Given this list of marker genes PRADC1, BICC1, HYPK, PPCS, ALG5, ZMPSTE24, TFB1M, TSEN2, VAPB, RPAP2, RAB14, PLPP5, CMPK1, SLC25A17, CACNA1F, FOXK2, SKIC8, XRCC6, NIP7, C11orf24 (NCBI Gene Id 53838, chromosome 11 open reading frame 24), FERRY3, MEMO1, RCC1, SGK2, CHST11, RRN3, RAPGEF5, NDUFB10, TCOF1 (treacle ribosome biogenesis factor 1), USP36, JAGN1, FBXL6, MRPL15, CLNS1A (NCBI Gene Id 1207), CEP55 (centrosomal protein 55), GARS1, DPY30, NHP2, C1D, SLC39A14, COQ9, GAS8, RGMA, GCAT, KIF20B, SOCS6, CNGB3, SH3PXD2B, PPIA, MRPS31, SLC36A4, BCAP29 (B cell receptor associated protein 29), DEPTOR, PRKCI, SLC36A1, UBFD1, RCC2, H2AZ1, FYTTD1, OPN1SW, PUM3, KDM4D, INPP5D, MPHOSPH10, TOP1MT, ATF5, DCTPP1, RAD17, DDX19B, EXOC2, EIF2B5, FADS6, IRF4, RAD51AP1, WDR12, CD5, PSMD1, PHF10, RNPS1, DAGLB, LIPT1, MYO7A, NDUFAF2, SEPTIN7, MYLK4, NDUFA13, SLC35A4, POP5, HACD1, MANF, EPPK1, PKM, PRIM2, TM6SF1, MTX2, MXD4, C2orf76, TDP1 (tyrosyl-DNA phosphodiesterase 1), CLPTM1L, NDUFS6, LRRC59, ATP5F1A, RPL10, C5orf24, GPR89B, BUB3, WASHC2A, CORO1C, WDR76, DDX20, PHTF2 (putative homeodomain transcription factor 2), HEATR1, GNAI3, PSMA1, RBM34, NUP85, TARS1, TSPY1, CIAO3 (cytosolic iron-sulfur assembly component 3), COPS7A, PYCR2, TYSND1, KDM2B, RIF1, GCSH, SDR39U1, BUD23 (NCBI Gene Id 84118), EXOSC1, KIF13A, CEP170B, E2F7, HCCS, NAA38, LALBA, NUP133, GNPAT (NCBI Gene Id 8443), RAP1GDS1, MPP3, SIRPA, PDE4DIP, UCHL5, TIMM10, PTGER2, KCNK7, ZWILCH, LBR, LPL, KNTC1, CELF5, CEBPZ, RBM28, SPRY3, DDX18, SET, GOLGA7, IL1RL2, NOP10, STRBP, NPM3, TARS2, MOB3B, STRAP, GLE1, GFM1, DLEU7, TFB2M, UBE2T, PIGY, KNL1, EMG1, LTV1, MANBA, CCDC47, MRPS9, TPM2, EIF3I, LCLAT1, IPMK, RPS6KA3, PPM1G, CCNA2, ZCCHC10, TATDN2, POPDC3, SLC4A7, NFU1, ATXN3, DHX29, SBK1, ATRN, ZSWIM7, RP9, MYADM, ALDH3A1, PRIM1, UTP4, EIF2B1, IMMT, P4HB, here is a description of the gene set: from publication Felker P, Seré K, Lin Q, Becker C, Hristov M, Hieronymus T, Zenke M (PMID 20881193) Dendritic cells (DCs) in lymphoid tissue comprise conventional DCs (cDCs) and plasmacytoid DCs (pDCs) that develop from common DC progenitors (CDPs). CDPs are Flt3+c-kitintM-CSFR+ and reside in bone marrow. Here we describe a two-step culture system that recapitulates DC development from c-kithiFlt3-/lo multipotent progenitors (MPPs) into CDPs and further into cDC and pDC subsets. MPPs and CDPs are amplified in vitro with Flt3 ligand, stem cell factor, hyper-IL-6 and insulin- like growth factor-1. The four-factor cocktail readily induces self-renewal of MPPs and their progression into CDPs and has no self-renewal activity on CDPs. The amplified CDPs respond to all known DC poietins and generate all lymphoid tissue DCs in vivo and in vitro. Additionally, in vitro CDPs recapitulate the cell surface marker and gene expression profile of in vivo CDPs and possess a DC-primed transcription profile. Transforming growth factor-β1 (TGF-β1) impacts on CDPs and directs their differentiation towards cDCs. Genome-wide gene expression profiling of TGF-β1-induced genes identified transcription factors, such as interferon regulatory factor-4 (IRF-4) and RelB, that are implicated as instructive factors for cDC subset specification. TGF-β1 also induced the transcription factor inhibitor of differentiation/DNA binding 2 (Id2) that suppresses pDC development. Thus, TGF-β1 directs CDP differentiation into cDC by inducing both cDC instructive factors and pDC inhibitory factors. Genes up-regulated in amplified: multipotent progenitors versus common dendritic cell progenitors. species: Homo sapiens Human Gene Set: GSE22432_MULTIPOTENT_VS_COMMON_DC_PROGENITOR_UP